The following is a description of a gene set: studied in species Homo sapiens In addition to receptor tyrosine kinases, the human genome encodes at least 32 non-receptor tyrosine kinases (non-RTKs). These cytosolic tyrosine kinases lack a transmembrane domain but are recruited into signal transduction cascades through interaction with other plasma-bound receptors, which may or may not themselves have intrinsic catalytic activity. In this way, non-RTKs essentially function as an (additional) enzymatic subunit of the signaling complex and contribute to many of the same downstream signaling pathways. The non-RTKs can be grouped into 9 families (ABL, SYK, JAK, TEC, FAK, ACK, SRC, BRK/PTK6 and CSK) based on their domain structure. part of: Signal Transduction Reactome Pathway: Signaling by Non-Receptor Tyrosine Kinases, and this is the list of marker genes: KRAS, CCND1, RAC1, NR3C1, LINC01139, GPNMB, RPS27A, UBC, SRMS, NRG3, EREG, STAT3, ELMO2 (engulfment and cell motility 2), PXN, EGF, SFPQ, ERBB2, PTK6, UBA52, EPAS1, CCNE1, CDKN1B, ARAP1, NRG1, ARHGAP35, HIF1A, RASA1, KHDRBS3, KHDRBS2, BTC, CDK2 (NCBI Gene Id 1017), DOK1, NRG2, HBEGF, ELMO1, UBB, AKT1, EGFR, STAP2, SOCS3, LRRK2 (NCBI Gene Id 399472), PELP1, CRK, CDK4, PTPN1, BCAR1, DOCK1, ERBB4, HRAS, NRG4, KHDRBS1 (KH RNA binding domain containing, signal transduction associated 1), NRAS, CBL, ERBB3, RHOA (ras homolog family member A)